Given this list of marker genes PTPRZ1, RSAD2, IRF1, LYN, PPIA, EIF4G3, TNFSF11, IL18, IFNG, CD36, HLA-DPA1, CUL1, NUP93, SMAD3, PTPN1, ZEB1, PSMD14, NPM1 (nucleophosmin 1), TEC, IFNLR1, CASP8, CSF2RB, TRIM68, UBE2E1, MAPK3, HCK, SEM1, GH2, HLA-DRB1, IL24, SEH1L, FCGR1A, ELOB, NUP214, HSP90AA1, TNFRSF9, IL33, HLA-DRA, VCAM1, MT2A, TOLLIP, CCL22, PTPN2 (protein tyrosine phosphatase non-receptor type 2), TUBB4B, TNFSF14, ICAM1, MAP2K6, TPR, IL7R, RIPK2, TUBA4A, SHC1, STAT1, SOCS5, INPPL1, MAPK10, NUP35, PRKACA, TRIM45 (tripartite motif containing 45), PTAFR, ADRM1, H3C3, TUBA1B, RANBP2, POM121, HLA-G, IL1RAPL1, EIF2S1, IL3, PSMA7, TUBA3C, EIF4E3, PSMD13, RPLP0, HSPA1A (NCBI Gene Id 3303), B2M, PSME2, SOS1, IL20RA, TAB2, IL1A, MIF, IP6K2, RPS27A, IL17RA, TNFRSF11A, POMC, GRB2 (growth factor receptor bound protein 2), SOCS1, TUBA1C, PELI3, ADAR, PRL, NUP107, IRF3, IL17RB, SOD2, NFKBIA, S100B, PSMB7, BIRC2, TRIM2, STX3, RAP1B, PPM1B, CD44, IL13, IFNL1, IRS1, UBE2N, SLA, PITPNA, SKP1 (NCBI Gene Id 6500), PDCD4, IL11RA, RHOU, IL13RA2, SIGIRR, GBP2, CDKN1A, TRIM8, ISG20, TRIM38, SYK, TRAF2, NOS2, LBP, CCL11, SNRPA1, STAT3, ITGAX, XAF1, PIK3R3, IL18BP, BCL2L1, RAG1, SRC, IFNA17, PSMC5, YBX1, KPNB1, FANCF, NUP58, HNRNPDL, CAMK2G, ATF2, PSMB2, OAS2, GATA3, IL27RA, IL6ST, CCND1, MAPK14, PSMC4, UBE2I, CIITA, IL36B, AGER, IL10RB, IL2RG, SMARCA4, FOS, IL2, HLA-B (major histocompatibility complex, class I, B), DUS2, STAT5B, NUP43, PSMB3, TUBA4B, FKBP5, TXLNA, SDC1, PSMB4, IL1R1, SUMO1, TRIM6, USP14, BOLA2, PSMB5, OAS1, GBP3, NFKB1, PSMB1, NUP54, CD86, PSMD1, IL9, HLA-DQA1, EGR1, FASLG (Fas ligand), GBP5, IFNA21, FANCB, IFNAR2 (NCBI Gene Id 3455), MMP3, FOXO1, NFKB2, CAMK2D, ILF2, IFIT2, MYD88, DNAJC3, IRAK1, DUSP6, FANCM, EDA, FLNB, EIF4E2, HSPA2, FN1, IFIT5, GSTO1, PSMD8, H3C1, SAA1, TRAF3, IFNA6, AAAS, PPP2R5D (NCBI Gene Id 5528), MAPKAPK3, CEBPD, TYK2, SOS2, TNFRSF6B, PRTN3, EIF4G1, TRIM29, IL36G, FANCC, MX1, BST2, EIF4G2, PSMA3, IL1RAP, CNTFR, TRIM48, IKBIP, ADAM17, DUSP3, GAB2, CSF1, IFIH1, NFKBIB, POU2F1, TBK1, UBE2L6, RPS6KA3, LMNB1, JAK3, BTRC (NCBI Gene Id 8945), IL1RL2, CUL5, GSTA2, GRB10, PTPN18, IL1R2, UBE2V1, IL22, NUP210, THOC5, IL3RA, ITGAM, IKBKG, HLA-DPB1, TNFRSF1A, PELI1, PTPN4, IL17RE, IL2RB, EDAR (NCBI Gene Id 1898), BOLA2B, PSMD11, HLA-DRB4, LRRC14, TAB1, ANXA2 (annexin A2), VAV1, PDE12 (NCBI Gene Id 201626), TNFRSF12A, AIP, FANCL, KPNA2, INPP5D, LCN2, PIM1, IGHG4, IL4, HGF, MAPK1, TRIM14, RAPGEF1 (NCBI Gene Id 2889), PTPRJ, TRIM21, TNFRSF25, LIFR, IRF7, IL22RA1, IRF4, CSF3R, PSMA2, SH2B1, MAPK7, FOXO3, PIK3CB (phosphatidylinositol-4,5-bisphosphate 3-kinase catalytic subunit beta), ITGB1, STX1A, TRIM3, CENPX, BATF, HNRNPF, YWHAZ, UBE2D2, POM121C, IL1B, PTPN6, H3C14, IL18R1, VRK3, AKT3, BCL2L11 (NCBI Gene Id 150819), KRAS, TNFRSF13B, IRAK3, TNFRSF4, TUBB8, CFL1, PTPN23, IRF6, LAMA5 (NCBI Gene Id 3911), JAK2, TRIM17, ITGB2, ANXA1, MAPT, FAAP100, NRAS, GBP6, MAPKAPK2, SAMHD1, RIGI, PIK3CA, TWIST1, RBX1, HIF1A, MID1 (midline 1), KPNA1, IL11, SQSTM1, HLA-E, IFITM3, LCK, LTBR, ARIH1, CTSG, HSPA1B, HAVCR2, EIF4A1, IL19, H3C7, BLNK, HSPA1L, H3C10, IL18RAP, TNFSF12, HMGB1, GBP1, IFNGR2, SOCS6, IRAK4, TRIM62, MAP2K1, SERPINB2, CSF1R, NOD1, OSM, CDK1, TRIM35, IL17C, GBP7, NCK1, IL36RN, UBC, CNTF, RORA, NEDD4, PSMB8, TRIM31, UBB, IL36A (interleukin 36 alpha), RAE1, H3C4, BECN1, CXCL1, PPP2R1A, CD40, SOCS2, CAMK2A, CDKN1B (cyclin dependent kinase inhibitor 1B), CBL, HLA-A, NDC1, RALA, EDA2R, PTPN12, COL1A2, ISG15, IL22RA2, IL37, HLA-C, HLA-DQB1, MCL1, NKIRAS1, FCGR1BP, YES1, LIF, LCP1, PSMC1, IFNA4, FANCG, SMAD7, IL13RA1, TRIM34, HLA-DRB5, IL23R, IL10, CCL4, EBI3, H3C12, EIF4A2, TIFA, PPP2CA, CREB1, NDN, CSK, PTK2B, HRAS, TNFSF13, CSH1, PIN1, ALPK1, IL12A, RAG2, PSMD12, IL2RA, IL25, TP53, FLT3LG, MX2, NUP37, FLNA, IFI6, CRLF1, IL21R, TARBP2, MAVS, LTB, PTPN13, TGFB1 (NCBI Gene Id 7040), TUBA3E, IL34, MAOA, IGHE, CRKL, NUP85 (NCBI Gene Id 83705, nucleoporin 85), SOD1, DHX9, MAP3K3, LTA, IFIT1, ALOX5, CAMK2B, PIK3CD, TIMP1, MMP1, IL27, ELK1 (ETS transcription factor ELK1), IFNA14, TNFRSF18, HLA-H, RELB, GH1, STAT2, PSMD6, NLRC5, NUP98, TNFRSF17, CD40LG, GSDMD, PIK3R2, CXCL8, BCL6, CCL3L3, ATF6, TCP1, FAAP24, IL20RB, NKIRAS2, PRLR, PIK3R1, FGF2, EIF2AK3, OSMR, TUBA8, CD80, F13A1, IL1RL1, CSF2RA, NUP153, CSF3, IFIT3, APP, HSP90B1, IL32, JAK1, PTPN9, PSMC6, IFNA7, PTPN14, NUP205, AKT2, TNFSF9, CD70, IFNA1, IFNA13, TRIM46, MAP3K7 (mitogen-activated protein kinase kinase kinase 7), SNAP25, HMOX1 (heme oxygenase 1), CLCF1, UBE2M, IRF9, FSCN1, IFI27 (NCBI Gene Id 3429), VAMP2, OPRD1, CXCL2, BRWD1, AKT1, PLCG2, SEC13, TNFSF4, IL7, IL5RA, NUP188 (nucleoporin 188), NUP155, USP18, MTAP (NCBI Gene Id 8008), NUP50, IFNGR1 (interferon gamma receptor 1), TAB3, JUN, IFI44, P4HB, TRIM5 (tripartite motif containing 5), PRKRA, RNF7, FBXW11, KPNA5, FLT3, FCER2, SLA2, GAB3, PLCG1, CASP3, IL12RB1, IRS2, HSPA5, MAPK11, TNFRSF8, UBA3, SPHK1, TUBB4A, IFI35, CAPZA1, OPRM1, JUNB, TRIM26, ABCE1, BIRC5, PPP2R1B, H3C2, FANCA, UBE2D3, NUP62, RNASEL, PTGS2 (NCBI Gene Id 5743), PSMA6, TUBB8B, SNCA, PSMD3, PSMA4, UBE2D1, PSMC3, NOD2, CCL20, VEGFA, CCR1, RELA, MAP2K3, H3C15, BIRC3, NANOG, MAPK9, CDC42, MAPK8, TUBB1, IL15RA, CTF1, MAP3K14, TUBB6, IFNL2, PTPN20, HSPA9, IL1F10, BCL2, HNRNPA2B1, DUSP4, IFI44L, RAF1, TUBAL3, PRKCD, SH2B3, N4BP1 (NEDD4 binding protein 1), PSMD2, FAAP20, IFITM2, TNFSF15, LGALS9, IFNAR1, IFNA8, NCAM1, UBA7, PELI2, IRF2, PIAS1, PPP2CB, MYC, IGHG1, PTPN11, IFNA2, IFNA16, CHUK, RPS6KA5, TUBB2B, MEF2A, CSF2, SP100, ATF1, PSMA1, CCR2, HLA-DQB2, FYN, MAP2K7, CCR5, TNFSF8, PSMB6, TNFRSF1B, S1PR1, CNN2, GBP4 (NCBI Gene Id 115361), EIF4A3, RPS6KA2, SOCS3, PPP2R5A, MMP9, MMP2, IRF5, TNFSF13B, ILF3, HLA-DQA2, IL9R, IKBKB, IL31RA, TNFSF18, PTPN5, IL15, HSPA8, EIF4E, STXBP2, SOX2, PSMA5, OAS3, IL20, IL6, IL17RC, TNIP2, OASL, PML, IL4R, H3C11, NUP133, MEF2C, IL17A, ARF1, CD4, GHR, IFNA10, IL12B, MSN, TNFRSF11B, HLA-DRB3, TNFRSF14, GRAP2, FPR1, DUSP7, CCL3, IFNL3, CXCL10, TUBB2A, H3C8, IL21, IL17F, PSMC2, STX4 (syntaxin 4), CISH, TUBB3, IRF8, UBA52, CRK, PAK2, IL10RA (interleukin 10 receptor subunit alpha), EIF2S2, EIF2AK2, TUBA1A, MAP3K8, ABL2, IL5, NUP88, IFNA5, H3C6, IL6R, EIF2S3, KPNA4, HLA-F, FANCE, NUP160, TRIM25, EDARADD, MUC1, VIM, HERC5, STAT5A, CASP1, TSLP, CENPS, IRAK2, IFNB1, VAMP7, IL16, TUBA3D, ELOC, S100A12, NLRX1, H3C13, KPNA3, TRIM22, CCL19, CRLF2, MAP2K4, IL1RN, RORC, PTPN7, RPS6KA1, STAT6, IFI30, CD27 (CD27 molecule), NUP42, IL23A, CCL5, CCL2, CANX, IL31, ALOX15, PSMD7, TNF, TALDO1, TNFRSF13C, IL12RB2, IFITM1, TRIM10, TRAF6, STAT4, KPNA7, IL26, CA1, here is a description of the gene set: studied in species Homo sapiens Human Gene Set: REACTOME_CYTOKINE_SIGNALING_IN_IMMUNE_SYSTEM Cytokine Signaling in Immune system